The following is a description of a gene set: studied in species Homo sapiens Human Gene Set: GOBP_NEGATIVE_REGULATION_OF_INFLAMMATORY_RESPONSE_TO_ANTIGENIC_STIMULUS Any process that stops, prevents, or reduces the frequency, rate, or extent of an inflammatory response to an antigenic stimulus., and this is the list of marker genes: RHBDF2, FGR, GPR17, FCGR2B, GPX1, YES1, MKRN2, NPY5R, SELENOS, FURIN (NCBI Gene Id 5123), HLA-DRB1, MIR302E, PSMB4, FYN, MIR105-1, PLK2, PSMA1, IL12B, TREM2, MIR19B1, MIR19A, SPN, SYK, NLRP6, LYN, MAPK14, NPY, GNAS, IL20RB, SRC, IL10, HCK, PLCG1, MIR6869